The following is a description of a gene set: Human Gene Set: chr19q12 studied in species Homo sapiens, and this is the list of marker genes: C19orf12, RPL9P32, TSHZ3 (teashirt zinc finger homeobox 3), LINC02959, LINC00906, UQCRFS1-DT, ENSG00000288017, LINC01834, CCNE1 (cyclin E1), ENSG00000266976, VSTM2B, TSHZ3-AS1, LINC02841, LINC01791, TAF9P3, ZNF536, URI1, UQCRFS1, LINC03103 (long intergenic non-protein coding RNA 3103), MAN1A2P1, PPIAP58 (NCBI Gene Id 126170), RN7SL340P, RNA5SP470, RNA5SP471, ENSG00000290606, VSTM2B-DT, LINC01532, PLEKHF1, POP4, RNU6-967P